Given this list of marker genes WT1, STAT5B, NEUROG1, WNT4, ODAD3, HOXA9, RRM1, CEBPB, ASB1, SAFB2, TEX11, DNAAF3, ESR1, TGFBR1, LFNG, DMC1, CASP2, CCDC182, HSD17B3, PRPS1L1, SALL1, ZP3, PTPRN, BRCA2 (NCBI Gene Id 82716), GATA6, DHH, DMRTA1, GMNC, TESC, CCNO, ARID4B, TGFB2, DMRT1, TEX19, EIF2B5, RAC1, ADAM29, STRA6, MSH2, IRX5, SGPL1, ZFPM2, NUP107, UBB (ubiquitin B), NR0B1, CDKL2, KDR, OSR1, ADCYAP1R1, TAF4, CSDE1, ADAM18, PKD1, TLR5, DHCR24, EREG, TLR3, LHCGR, AMHR2, NRIP1, AMH, HMGB2, CNTFR, ADAM32, NPPC, FANCG, ABCB1, CITED2, GREB1L, PLEKHA1, FOXO3 (NCBI Gene Id 2309), HESX1, CHD7, SFRP2, SOD1, ZFY, SCX, LEP, GFRA1, CSMD1 (CUB and Sushi multiple domains 1), TSPY8, SIX4, ANG, TLR9, PRDX4, MIR455, CGA, FLNA, LSM14B, FGF9, FNDC3A, BIK, UBE3A, CTNNB1, TSPY3, BMPR1A, SRD5A1, H3-3A, WDR48, HOXA13, NOTCH4, CYP17A1, RBP4, MAMLD1, FGF8, NPR2, NKX2-1, AGO4, TYRO3, PCYT1B, TIPARP, NR5A1, NUP210L, LHB, FER, SMAD5, FST, NIPBL, ADGRG1, CCND1, DNAAF11 (dynein axonemal assembly factor 11), FOXC1, BMP5 (NCBI Gene Id 653), PTPN11, TMF1, NTRK1, NR2F2, ADAM2, HSD17B4, RNF38 (NCBI Gene Id 64796), DMRTA2, PATZ1, SOX9, KIF18A, GAS2, CASP3, VGF, AFP, ATN1, AKR1C3, ATM, INHBA, PRKACG, MMP19, DMRT2, KITLG, TBX3, DMRTC2, BCL2L2, BOK, SOX15, SMAD4, PBX1, BCAS2, DACH2, HNF1B, SPO11, BAK1, RBMY1B, LHX9, FANCA, H3-3B, HNF4A, SIRT1, INHBB, RAB13, BMPR1B, RHOBTB3, SCAPER, CYP19A1, DCANP1, TSPY10, AXL, FSHB, CTNNA1, LHX1, TFAP2C, TIFAB, FSHR, BCL2L11, NR5A2, YBX3, VEGFA, ING2, CENPI, CD2AP, WNT5A, HOXA11, INHA, LGR4, MEA1, BCL2, SFRP1 (secreted frizzled related protein 1), LRP2, DMRTB1, ACVR2A (NCBI Gene Id 92), WDR19, GNRH1, UMODL1, MSH4, SYCP2, HYAL3, STAT5A, IDH1, NHLH2, NASP, FANCE, NUPR1, RDH10, WNT7A, ADAM20, DMRT3, SIX3, WNT2B, TNFAIP6, FGF10, BASP1, BAX, KLHL10, GDF9, TSPY9, TSPY4, AR, HMGA2, ARID4A, RETN (resistin), MMP14, MERTK, RXFP2, TCF21, NOS3, SHH, ARID5B, NOTCH1, GATA3 (GATA binding protein 3), GPR149, SRD5A2, CRKL, EIF2S2, NCOA1, HOXD13, MKKS, MCIDAS, PTX3, FKBP4, DACH1, ZNF830, ACE, TSPY2, KIT, FOXL2, SLIT3, SLIT2 (NCBI Gene Id 9353), FZD4, SRY, PDGFRA, ZFP42, SOX8, ASPM, RARA, PGR, IMMP2L, LHFPL2, EIF2B4, EIF2B2, FOXF2, CBX2, DNAJC19, ADAMTS1, BCL2L1, WNT9B, ROBO2, UTF1, SPATA2, REC8, NKX3-1, GATA4, NCOA4, BRIP1, INSR, ADAM21, DHX37, MMP2, TBC1D20, GATA1, BMP6 (bone morphogenetic protein 6), TP63, ADAM30, ATRX, REN, CBL, CNOT9, HOXA10, ERCC1, TSPY1, ADAM15, here is a description of the gene set: Human Gene Set: GOBP_SEX_DIFFERENTIATION species: Homo sapiens The establishment of the sex of an organism by physical differentiation.